The following is a description of a gene set: Cancer cells differentiate along specific lineages that largely determine their clinical and biologic behavior. Distinct cancer phenotypes from different cells and organs likely result from unique gene expression repertoires established in the embryo and maintained after malignant transformation. We used comprehensive gene expression analysis to examine this concept in the prostate, an organ with a tractable developmental program and a high propensity for cancer. We focused on gene expression in the murine prostate rudiment at three time points during the first 48 h of exposure to androgen, which initiates proliferation and invasion of prostate epithelial buds into surrounding urogenital sinus mesenchyme. Here, we show that androgen exposure regulates genes previously implicated in prostate carcinogenesis comprising pathways for the phosphatase and tensin homolog (PTEN), fibroblast growth factor (FGF)/mitogen-activated protein kinase (MAPK), and Wnt signaling along with cellular programs regulating such 'hallmarks' of cancer as angiogenesis, apoptosis, migration and proliferation. We found statistically significant evidence for novel androgen-induced gene regulation events that establish and/or maintain prostate cell fate. These include modulation of gene expression through microRNAs, expression of specific transcription factors, and regulation of their predicted targets. By querying public gene expression databases from other tissues, we found that rather than generally characterizing androgen exposure or epithelial budding, the early prostate development program more closely resembles the program for human prostate cancer. Most importantly, early androgen-regulated genes and functional themes associated with prostate development were highly enriched in contrasts between increasingly lethal forms of prostate cancer, confirming a 'reactivation' of embryonic pathways for proliferation and invasion in prostate cancer progression. Among the genes with the most significant links to the development and cancer, we highlight coordinate induction of the transcription factor Sox9 and suppression of the proapoptotic phospholipid-binding protein Annexin A1 that link early prostate development to early prostate carcinogenesis. These results credential early prostate development as a reliable and valid model system for the investigation of genes and pathways that drive prostate cancer. Human Gene Set: SCHAEFFER_PROSTATE_DEVELOPMENT_48HR_UP from publication Schaeffer EM, Marchionni L, Huang Z, Simons B, Blackman A, Yu W, Parmigiani G, Berman DM (PMID 18794802) studied in species Mus musculus Genes up-regulated in the urogenital sinus (UGS) of day E16 females exposed to the androgen dihydrotestosterone for 48 h., and this is the list of marker genes: ATP2C2, GPRC5B, FAM110C, ATP8A2, CSPG5, NKX3-1, ADGRG2, PENK, RPRM, BSPRY, TMEM184A, KCNJ16, BDH2, LRATD2 (LRAT domain containing 2), CITED2, IRS4, C1orf116 (NCBI Gene Id 79098), SORBS2, ASPN, HKDC1, AIF1L, SMOX, ERRFI1 (ERBB receptor feedback inhibitor 1), SERTAD4, ALDH6A1, PTS, CRISPLD2, TCIM, EPHA3, GGACT, ID3, SMAGP, DENND2D, LYPD2, MROH4P, TMEM9B, MBP, PLA1A, SSR3, EMB, ZFYVE21, CYS1, ST3GAL1, FXYD4, LYNX1, EMP2, SYNPR, PDGFC, ABHD12, MBOAT1, LRRK1, MYO3B, ZBTB8B, LLGL2 (LLGL scribble cell polarity complex component 2), CALB1, ANO1, SDR42E1, PLXNA2, PKP3, FDX1, ACAA2, ALOX12, SPINT1, CLU, PLA2G4A, ALDH1A2, RIPOR3, PLCH2, SLCO4C1, LORICRIN, CEACAM1, TMEM44, RIPPLY3, AGR2 (NCBI Gene Id 10551), TUFT1, RBBP7, BCL2L1, SLC1A5, CLCA1, SDHAF2, CROT, PTGR1, RDH10, SULT1E1, FKBP5, PTGES, LEPROT (NCBI Gene Id 83080), UPK2, CYP7B1, N6AMT1, CEMIP, ALDH1A1, SP6, RETREG3, CCBE1, ITGB4, MACIR, PSCA, FGFR3, DYNLT1, GAS6, RNASE4, EPHX2, GSDMC, RAB3IP, PSAPL1, EDARADD (EDAR associated via death domain), MPP7, PIGF, LAMP2, KDM5D, SELENOF, OTULINL, OR2AK2, SLITRK6, GSN, NRN1, SP5, DRAM2, TRPV4, ANXA3, KRT15, SLC16A7, HEBP2, KRT78, ACKR3, SH3YL1, TMPRSS2, KIAA0040, SERINC3, ADAMDEC1, ENTREP2, PHLDA3, KLF15, GLP2R, GABARAPL2, SLC2A12, NT5E, COL6A4P1, PTN, LMO4, DLG3, VPS37B, LRRC26, SKAP2, MAP3K5, ERP29, IGFBP2, CYSTM1, SOX9, ANXA1, CARD19, SFRP2, ARHGEF26, PLET1, GATA3, GPR155, MAF, ACSS1, TMEM35B, RNF128, GSTT3P, KCND2, WNT4, ERMP1, HOPX, KRT19, RAMP1, FGF12, DUSP14, NMRK1, CALM1, NFKBIA (NFKB inhibitor alpha), ANXA9, COL9A3, ASB13, FXYD3, AFM, ALDH1A3, TMEM51, CA14, CD24, SPINK8, SAR1B, BEND4, PCOLCE2, TWF2, EIF2S3, COL4A6, MKX, SGK1, USP6NL, PLCD1, RSPO3, PCDH9, EDN1, TRPV6, TRIM2, SCT, COL24A1, VAMP8, CYP1B1, SPINK5, CYP26A1, SEC11C, ADAMTSL2, SLC31A2, LY6G6E, TSC22D3, CEBPD, S100A14, SLC39A8, HDAC9, CLDN23, ID2, GSPT2, STAT5A, INSL6, HOXD8, HOXB13, NAMPT, NAPSA, C5orf15, USP2, LY6E, ACOT1, PLS3, ABCC4, CRYBG1, NQO1, EVA1C, EPCAM, SLC25A30, MFSD2A, TMEM117, ADGRB1, DCDC2, PANTR1, NSMCE3, DNASE1L2, CXCR4, TACSTD2, MANBA, RAB17, AHCYL2, LANCL3, ITM2B, PIAS1, SIPA1L1, GLB1L2, SCNN1A (NCBI Gene Id 6337), MAP3K21, TIPARP, SUOX, TESC, ARC, IL33, CORO2A, GPLD1, HLA-B, DCXR, BDH1, KCNK1, CLIC6, TMC4, C6orf132, TCF15, FAM83H, BHLHA15, BRI3, TFAP2C, NKPD1, ERP44, IL13RA2, ENDOD1, TST, NCK2, AOC1, ATP1A1 (ATPase Na+/K+ transporting subunit alpha 1), ATXN1-AS1, CHP1, SNTA1, SPTSSA, TSPAN12, LYRM4, EPPIN, MANF, SALL3, NRIP1, WNK2, PHYHD1, CTSO, NALF1, ESM1, C9orf85, TINAGL1, KRT23, SMOC1, TFCP2L1, CALCA, RAB15 (RAB15, member RAS oncogene family), MT1X, DHRS3, RAB25, PID1, HSD17B12, SULT1A1, ACSM3, SUSD3, ERGIC1, CDH8 (NCBI Gene Id 1006), MDFI, ELF3 (E74 like ETS transcription factor 3), ARHGEF16, PNPT1, GDPD2, GDPD1, GRP, M6PR (NCBI Gene Id 4074), B3GNT8, FUT9, KRT13, ELOVL2, COLGALT2, EMC4, CALCRL, HPGD, CPM, RALGPS2 (NCBI Gene Id 55103), MTHFD2, IGSF5, PLAC8, KCNMB4, CAMK4, DMRTC1 (NCBI Gene Id 63947), DUSP6 (dual specificity phosphatase 6), KLF9, TMTC4, MICALL1, RGS2, LEPROTL1, DDX3Y, FAM149A, TRMT9B, ADARB2, COL4A5, TTC6, RAB11A, PDGFD, PROS1, SLC36A2, WIF1, TPD52L1, ABCA5, AGTR1, TSEN15, TMEM37, AQP3, ECM1, XPR1, PPFIBP2, GCLC, MASP1, RASD1, NUDT7, GADD45G, PLSCR1, ARHGAP20, ADH1A, BCL2, FOXA1, SLC5A9, FAM162B, TAPBPL, GNG12, EAF2, DDIT4L, KCNN4, SHH, PLLP, MAFB, CAPN5, CDH16, CDH1, SEMA3B, DNER, VLDLR, EFEMP1, GLUL, CYTH3, CFAP20DC, TLE6, FGFR2, NXF1, ARHGEF5, ANKRD1, DIO3, CYP2F1 (NCBI Gene Id 1572), TMEM40, BBS9 (Bardet-Biedl syndrome 9), RASL11B, TRHR, LMCD1, MMP7, FAM3C, TMC7, GPX2, TENM1, TMED6, TSPAN13, TSPAN1, RCSD1, TBPL1, BATF3, MIEN1, CCDC198, C11orf54, WNT9B, ADAMTS16, ALDH3B2, RNF32, SLCO2A1, ADGRG1, UBQLN2, PTPN13, PDLIM2, MRPS6, ACSL4, PROM2, MPI, KRT7, COBLL1, AFF1, ID1, SPRR1A, CLDN4, LYPD6, MYOF, ISCU, PRR15, HHIP, HMGN3, WNT6, MEIG1, RAB5C, LPAR6, SLC9A2, NIPAL1, MAPK13